The following is a description of a gene set: Mouse Gene Set: GOCC_COATED_VESICLE Small membrane-bounded organelle formed by pinching off of a coated region of membrane. Some coats are made of clathrin, whereas others are made from other proteins. species: Mus musculus, and this is the list of marker genes: Ap1g1, Ccdc115, Atp6v0b, Astn1 (NCBI Gene Id 11899), Sec24a, Vwf, Tnk2, Pacsin1, Cracr2a, Vps33b, Pheta2, Actr1a, Cltc, Vti1b, Pik3c2a, Yipf6, Yif1a, Fcho2, Tmed9, Ccdc88a, Btbd8, Cnih4, Atp6v1e1, Trf, Syt11, Gak, Tmed10, Dvl1, Dennd1c, Spg21, Dnm2, Ap1s3, Atp6v1h, Pef1, Aak1, Ctla4, Copb2, Kdelr1, Yif1b, Igf2r, Rab13, Sec24c, Dbnl, Golga2, Nrgn, Rgs19, Tmem199, Slc17a8, Sec24d, Rab35, Gas7, Gad2, Ap3b1, Ier3ip1, Pdcd6 (programmed cell death 6), Clba1, Snap91, Hspd1, Atp6v1g2, Ddhd2, Atp6v1d, Atp6v1a, Arcn1, Cpne2, Vps33a, Copz2, Atp6v0d1, Ston2, Sec23ip, Plcg1, Tmed6, Scyl1, Gad1, Slc30a5 (NCBI Gene Id 69048), Srebf1, Ap2s1, Ap1m2, Slc2a4, Sar1a, Rassf9, Dnm1, Epn1, Abcb4, Ap1m1, Epn2, Gopc (NCBI Gene Id 94221), Ergic1, Sec24b, Copb1, Fcho1, Copz1, Srebf2, Ecpas, Rab3a, Synrg, Yipf5, Aftph, Ap3b2, Ap1s1, Vps41, Cubn, Lman1l, Pacs1, Uso1, Rab27a, Lman2l, Clint1, Stx17, Sec23a, Sec22b, Gga2, Hip1r, Vps11, Ap2m1, Lman1, Scap, Sec13, Ap1g2, Picalm, Slc28a2b, Cpne6, Clrn1, Enthd1, Arc, Dennd1a, Lyz1, Vps16, Wipi1, Snx9, Use1, Sec31a, Vangl2, Gnas (GNAS complex locus), Ergic3, Slc28a2, Atp6v0e2, Lman2, Vti1a, Tepsin, Rab8b, Snx3, Surf4, Rab27b, Unc13d, Sec31b, Aqp2, Ston1, Sar1b, Rab14, Bcap31, Vma21, Golga5, Sec23b, Hax1, Scyl2, Ap1b1, Atp6ap1, Reep6, Vps18, Dnajc6, Ergic2, Vamp2, Inpp5f, Gosr2, Dennd1b (DENN domain containing 1B), Ap1s2, Copa, Myo6, Pheta1, Myo1e, Tbc1d5 (NCBI Gene Id 72238), Kdelr2, Syp, Copg2, Clvs2, Necap2, Atp6v1b2, Atp7a, Gpr107, Ap4b1, Sgip1, Klhl12, Atp6v0c, Tgoln1, Smn1, Sort1, Cemip, Pcsk9, Lrp1, Ap2a2, Sec16b, Folr1, Dipk2a, Tmed2, App, Epn3 (epsin 3), Dab2, Pank1, Tmed3, Rnf216, Cltb, Tmed1, Tmed7, Numb, Clta, Tex261, Htt, Atp6v1c1, Atp6ap2, Tmed11, Heatr5b, Ngfr, Tyrp1, Dnajc5, Kdelr3, Sh3bp4, Ocrl, Vamp3, Slc5a7, Clvs1, Ap2b1, Lmbrd1, Adcy8, Edn1, Hip1, Cope, Scamp1, Snx18, Cideb, Steap2, Eps15, Adam10, Astn2, Tmed4 (transmembrane p24 trafficking protein 4), Sec16a, Necap1, Syn1, Otof, Atp6v0a1, Arf1, Mall, Ap2a1, Furin, Rab12, Slc18a3, Tmed5, Lyz2, Rnasek, Ece1, Copg1, Rab8a, Dvl2, Bnip1, Atp6v1f